Given this list of marker genes AGO4, AGO1, AGO2, PRKRA, ADAR, DHX9, TARBP2, AGO3, DICER1, CLP1, here is a description of the gene set: The process in which a single-stranded small RNA is incorporated within the RNA-initiated silencing complex (RISC). The assembly includes the maturation of the small RNA, the stabilization of the complex by accessory proteins of the RISC complex, duplex separation and the release of the second strand, forming a base-pairing complement complex that mediates gene silencing by small RNA. studied in species Homo sapiens Human Gene Set: GOBP_RISC_COMPLEX_ASSEMBLY